Given this list of marker genes LAMB3, SLC26A9, CD19, MS4A1, IFNGR1, SLC6A14, ODAD3, GATA6, MBL2, LAMC2, DNAAF4, PGM3, SLC37A4, RAB27A, UNG, NFKBIA, NTRK1, NME5, CEACAM6, MIF, LAMA3 (laminin subunit alpha 3), TBCE, SLC7A7, ZAP70, PSENEN, IGHG2, MCIDAS, CEACAM3, ISG15, ELANE, TNFRSF13C, ITGB2, FOXJ1, DNAAF5, IKBKG, ODAD1, CD8A, GJB2, ARPC5, CD81, CYBA, SCNN1A, SLC11A1, AICDA, MST1, CEBPE, ODAD4, WAS, ADA, DNAJC21, KCNN4 (NCBI Gene Id 3783), HAX1, DNAAF2, EDNRA, KNSTRN, CCDC40, CLPB, CTSC, TLL1 (NCBI Gene Id 7092), CLCA4, IGKC, DNAI1, CD40 (CD40 molecule), ANTXR2, SLC39A7, MAP3K14, FERMT3, ODAD2, GJB6, UBE2A, NKX2-5, HBB (NCBI Gene Id 3043), CD40LG, DNAI2, ICOS, EPHB4, LRRC56, DOCK8, GPR35, DNAAF6, C5, C3, NME8, DNAJB13, TCF4, DNAAF11, SERPINA1, GFI1, GATA1, DNASE1L3, SH3KBP1, IRF1, IL12RB1, TBX20, GATA4, STAT1, CR2, PIK3CD, RFXAP, DNAH9, DNAAF3, RSPH9, DNAAF1, SPEF2, SLC9A3, MALT1, GSTM3, IGHM, OFD1, FOXN1, IL2RA, RFX5, ATP6AP1, RAG1, IGLL1, CFAP74 (cilia and flagella associated protein 74), BLNK, SPAG1, CFAP298, IL2RG, STX1A, RSPH1, CFI, HMOX1, CFB, IKZF1, AP3B1, EPG5, BTK, GAS2L2, DNAH11, STK4, CCNO, DRC1, RAG2, UROD, G6PC3, HYDIN, GCLC, SEC61A1, CYBB, RFXANK, SCNN1B (NCBI Gene Id 6338), POLD3, CITED2, PSEN1, SMARCD2, CCDC39, SLC35A1, DNAH5, NEK10, CFAP221 (cilia and flagella associated protein 221), JAGN1, DNAH1, TTC12, RBCK1, NCF2 (neutrophil cytosolic factor 2), SAMD9, SBDS, CFAP300, MAN2B1, HFE, TYK2, NHEJ1, PNP, RNF31, MBTPS2, TNFRSF13B, CD79B, C8B, DEF6, GATA2, RPGR, C6, LYST, DCTN4, CXCR4, IRAK4, C7, CFD, STAT3 (NCBI Gene Id 6774), RSPH4A (NCBI Gene Id 345895), SCNN1G (sodium channel epithelial 1 subunit gamma), NCF1, STIM1, CFTR (NCBI Gene Id 1080), ZMYND10, EFL1, MYH6, FCN3, IL17RA, IL10RA, RSPH3, CD79A, POMP, SRP19 (signal recognition particle 19), TGFB1, CFH (NCBI Gene Id 3076), STK36, DNAL1 (NCBI Gene Id 83544), DCLRE1C, ACTC1, SEMA4D, IFNGR2, CARMIL2, OTULIN, ADAM17, LCP2, TCIRG1, UROS, PIK3R1, CIITA (class II major histocompatibility complex transactivator), EGFR, IKZF3, here is a description of the gene set: Recurrent bacterial infections Human Gene Set: HP_RECURRENT_BACTERIAL_INFECTIONS studied in species Homo sapiens Increased susceptibility to bacterial infections, as manifested by recurrent episodes of bacterial infection.